Given this list of marker genes Uba52, Fgf15, Shc1, Grb2, Ubc, Mapk3, Fgf18, Fgf1, Fgfr4, Kras, Mknk1 (MAP kinase-interacting serine/threonine kinase 1), Cbl, Sos1, Fgf2, Fgf9, Ppp2ca, Fgf16, Gab1, Klb, Fgf6, Fgf4, Frs2, Fgf8, Hras, Fgf20, Fgf17, Uba52rt, Ubb, Braf, Plcg1, Pik3r1, Src (Rous sarcoma oncogene), Frs3, Ppp2r1a (protein phosphatase 2, regulatory subunit A, alpha), Ptpn11, Rps27a, Ppp2cb, Fgf23, Pik3ca (NCBI Gene Id 70742), Spry2, Mapk1 (NCBI Gene Id 98012), here is a description of the gene set: Signaling by FGFR4 species: Mus musculus Mouse Gene Set: REACTOME_SIGNALING_BY_FGFR4